Given this list of marker genes NFKB2, IKBKB (inhibitor of nuclear factor kappa B kinase subunit beta), NFKBIA, IKBKG, NFKB1, RELA, CHUK, here is a description of the gene set: studied in species Homo sapiens Reactome Pathway: IkBA variant leads to EDA-ID The nuclear factor kappa B (NFkB) family of transcription factors is kept inactive in the cytoplasm by the inhibitor of kappa B (IkB) family members IKBA (IkB alpha, NFKBIA), IKBB (IkB beta, NFKBIB) and IKBE (IkB epsilon, NFKBIE) (Oeckinghaus A and Ghosh S 2009). Multiple stimuli such as inflammatory cytokines, microbial products or various types of stress activate NFkB signaling leading to stimuli-induced phosphorylation of IkB molecule (Scherer DC et al. 1995; Alkalay I et al. 1995; Lawrence T 2009; Hoesel B and Schmid JA 2013). The phosphorylation of IkB proteins triggers their polyubiquitination and subsequent degradation by 26S proteasome, allowing free NFkB dimer to translocate to the nucleus where it directs the expression of target genes. Studies have identified an autosomal dominant form of ectodermal dysplasia with immunodeficiency (AD-EDA-ID) caused by a hypermorphic heterozygous mutation of NFKBIA/IKBA gene. The IKBA defects prevent the phosphorylation and degradation of IKBA protein resulting in gain-of-function condition with the enhanced inhibitory capacity of IKBA in sequestering NF?B dimers in the cytoplasm (Courtois G et al. 2003; Lopes-Granados E et al. 2008; Schimke LF et al. 2013). part of: Diseases associated with the TLR signaling cascade